Given this list of marker genes Arnt2, here is a description of the gene set: This event has been computationally inferred from an event that has been demonstrated in another species.<p>The inference is based on the homology mapping from PANTHER. Briefly, reactions for which all involved PhysicalEntities (in input, output and catalyst) have a mapped orthologue/paralogue (for complexes at least 75% of components must have a mapping) are inferred to the other species. Reactome Pathway: Aryl hydrocarbon receptor signalling electronically inferred by orthology from the curated human pathway part of: Phase I - Functionalization of compounds studied in species Mus musculus